Given this list of marker genes Chmp1a, Chmp3, Myof, Chmp1b, Chmp2b, Chmp4b (NCBI Gene Id 96954), Chmp4c, Vps4a, Prf1, Casp1, Smpd1, Syt7, S100a10, Sytl4, Myh10, Cav3, Chmp6, Dysf, Fer1l5, Chmp1b2, Casp7, Trim72, Myh9, Chmp5, Anxa2, Syt11, Gsdmd, Ano5, Rab3a, Arl8b, Chmp7, Gzmb, Chmp2a (NCBI Gene Id 68953), Vps4b, here is a description of the gene set: species: Mus musculus Mouse Gene Set: GOBP_PLASMA_MEMBRANE_REPAIR The resealing of a cell plasma membrane after cellular wounding due to, for instance, mechanical stress.